The following is a description of a gene set: Activation of G protein gated Potassium channels studied in species Mus musculus Mouse Gene Set: REACTOME_ACTIVATION_OF_G_PROTEIN_GATED_POTASSIUM_CHANNELS, and this is the list of marker genes: Kcnj4, Gng11, Gng8 (guanine nucleotide binding protein (G protein), gamma 8), Gng13, Gng2, Gnb2, Gnb4, Gng5, Gng3, Kcnj16, Gnb5, Gng4, Kcnj5, Kcnj6, Kcnj9, Gabbr1, Kcnj10, Gnb3, Gnb1, Kcnj2, Kcnj3, Gng12, Gngt1, Gng10, Gngt2, Kcnj15 (potassium inwardly-rectifying channel, subfamily J, member 15), Gabbr2, Gng7, Kcnj12 (NCBI Gene Id 16515)